Given this list of marker genes CYLD, EIF5AL1, NDFIP1, JAG2, NMNAT3 (nicotinamide nucleotide adenylyltransferase 3), TRUB2, LSR, KLHL2, DERA, ZNF347, NRCAM, MSH3, SUN1, DGCR2, here is a description of the gene set: Genes predicted to be targets of miRBase v22 microRNA hsa-miR-1277-3p in miRDB v6.0 with MirTarget v4 prediction scores > 80 (high confidence targets). species: Homo sapiens from publication Chen Y, Wang X (PMID 31504780) Human Gene Set: MIR1277_3P